The following is a description of a gene set: Human Gene Set: GOBP_CEREBRAL_CORTEX_REGIONALIZATION The regionalization process that results in the creation of areas within the cerebral cortex that will direct the behavior of cell migration and differentiation as the cortex develops. studied in species Homo sapiens, and this is the list of marker genes: ADGRG1, TRA2B (transformer 2 beta homolog), EMX1, PAX6, DMRTA2, EMX2, EOMES